Given this list of marker genes SUGT1, ANHX, SIX1, EPHB1, MYOG, MEGF10, ANGPT1, PAXBP1, CFLAR, AKIRIN1, NDC80, STAT3, JAK2, MYB, SIX5, FGF2, MSTN, CAV2, DSN1, KPNA1, HGF, SELENON, SHH, PPARD, FOS, here is a description of the gene set: studied in species Homo sapiens Human Gene Set: GOBP_SKELETAL_MUSCLE_CELL_PROLIFERATION The multiplication or reproduction of skeletal muscle cells, resulting in the expansion of a cell population.